Given this list of marker genes SLC30A8, CPE, IER3IP1 (immediate early response 3 interacting protein 1), P4HB, IDE (insulin degrading enzyme), CEACAM1, CTSD, PCSK2, NLGN2, JAGN1, CELA2A, ERN1, FOSL2, SLC30A5, PCSK1, YIPF5, ERO1B, HID1, here is a description of the gene set: The chemical reactions and pathways involving insulin. Human Gene Set: GOBP_INSULIN_METABOLIC_PROCESS studied in species Homo sapiens